Given this list of marker genes MAP3K20, HEPHL1, NOG, TBC1D2B, RAB3GAP2, TBX5, COG8, EOGT, BCOR, FRA10AC1, PPP2R5D, here is a description of the gene set: Human Gene Set: HP_ABNORMAL_FOURTH_TOE_MORPHOLOGY species: Homo sapiens Abnormal fourth toe morphology An anomaly of the fourth toe.